The following is a description of a gene set: studied in species Homo sapiens Genes predicted to be targets of miRBase v22 microRNA hsa-miR-7106-5p in miRDB v6.0 with MirTarget v4 prediction scores > 80 (high confidence targets). Human Gene Set: MIR7106_5P from publication Chen Y, Wang X (PMID 31504780), and this is the list of marker genes: INKA2, ARID2 (NCBI Gene Id 57676), GAB2, CREB3L2, ATF6 (NCBI Gene Id 22926), ZXDA, MPP2, ANKS4B, ZNF814, SP8, PAPOLG, ARG2, IRGQ, WDR64, SARDH, PURG, MAP3K13 (NCBI Gene Id 9175), ARL6IP5, TPCN1, TMEM14B (transmembrane protein 14B), TRAF3IP2, CYP1A2, PDLIM7 (PDZ and LIM domain 7), POLDIP3, SRGAP1, DENND2B, MTFP1, ALS2, ABHD4, ENTPD5, RIMS3, BAZ2A, ANO6, HRH2, NDST1 (NCBI Gene Id 3340), CRTC2, OSBPL1A, PTPRB, PRR12, VWA5B2, AGPAT1, NCKAP1L, VPS13B, CORO2B, FNDC5, FGFBP3, PLCXD1, TMEM164, KLK4, N4BP1, HOXC10, COG5, PI3, GDF11, CES4A, TBC1D24, MIP, SDK1, CNEP1R1, GNAT1, ABCG4, PDLIM2, ACKR2 (atypical chemokine receptor 2), FBN2, BLOC1S3, NFAT5, SHISA7, BAK1, NACC1, MARK4, MAML1, TOM1L2, ERLIN2, SMUG1, CACNG7 (calcium voltage-gated channel auxiliary subunit gamma 7), CBX5, LEPROT, CGNL1, MYO10, XPO4, IMPDH1, TMEM239, TBC1D20, ZNF674, POU2F2, SCAI, SKI, VAT1, DNAJC8, DLG5, SLC25A45, DAB2IP, KANK2, GM2A (NCBI Gene Id 2760), NOS1, CEBPZOS, TMED10, ZNF544, CALCR, CDC20B, PHACTR4, APOBEC3F, MAPK13, SUSD5, TNRC6A, DERL1 (derlin 1), NCEH1, EXPH5, PACS1, ISLR, ELK1, TMEM63C, IRAK3, CCL28, EFNB3, FURIN, COPS7B, IGF2BP1, TFDP2, TEAD2 (TEA domain transcription factor 2), ITLN1, CREB5, SENP5, SPINDOC, CAST, AR, NFASC, CPLX2, PPIL3, RALB, SIDT2 (SID1 transmembrane family member 2), SLC2A4, USP54, HPDL, ZNF639, HP1BP3, EEIG1, SYPL2, AHDC1, MOB3A, SHOX, ZHX3, ZNF385A, BTF3L4, NANP, IDS, SV2C, GPLD1, RBM19, DHH, GYG2, IQSEC1, ZNF365, PFN2, FNIP1 (folliculin interacting protein 1), FTCD (formimidoyltransferase cyclodeaminase), ZNF177, POU2AF1, RBM23, PLEC (plectin), ZNF559-ZNF177, BMP8A, CYP20A1, PSORS1C1, PSMB2 (NCBI Gene Id 5690), IKZF3, SH3BP2 (NCBI Gene Id 91018), ELMO1, P4HA1, PAX2, EIF4EBP2, CDH1, VIRMA, NMNAT2, PCBD2, NECTIN1, PKP1, MDM4 (MDM4 regulator of p53), ZNF554, MARK2 (NCBI Gene Id 2011), CD164, STK25, IGFBP5 (NCBI Gene Id 3488), GIPR, MAVS, MUCL3, AVL9, ATF7IP2, TSPAN31, HNF4A, RAD51B, CS, EPS15L1, SYBU, PRKCA, EEF2K, CCND3, PAX7, NOVA2, NEK2, SORBS3, CTNNA3, ODAPH, PACSIN1, UBXN2B, NAV1, HUNK, OAS3, ATXN2L, FOXK1, PRICKLE3, ASPG, PPP1R11, KCNJ6, EFCAB2, RGS5, SLC7A8, ORAI2, SLC4A8, WFDC1 (WAP four-disulfide core domain 1), LRP4, CLSPN, ATXN7L3, RRP15, TNFSF9, FGF23, DACT2, CADM3, JPH4, ZNF501, GNAO1, STK39, MYOZ2, RPL15, HERC3, NALF1, PLEKHA5, SART1, PPIE, MPV17L, VPS25, CPNE4, KCND1, GRIP2, HDAC9, CSDC2, KNCN, ZNF354C, PAQR4, PPM1F, ZNF497, TMTC1, CASP10, MYO1D, NCR3LG1, SLC36A3, MAT2A, APOL6, PDPN, SAMD4A, SNU13, SLC6A11, AIF1L, GTDC1, THBD, FOXP4, TXNDC12, A1BG, KIAA0513, RBMS2, PNPO, TOMM40L, RNF114, LZTS3, JPH2, UBE2D4, NRIP2, RNF103, CSNK1G3, VAMP1, CENPO, HECTD4, EOGT, DEPDC5, TIAM1-AS1, SYT2, TEX261, GRID2, IQGAP1, PRND, ARF5, SYT15, GPT2, TSPYL5, DBP, ARL4D, ZSCAN26, ARHGEF11, MPIG6B, MTCL2, OGFOD1, SEPTIN3, CASTOR2, GRM5, SHISA6, KCNIP1, FBXL20, SCG2, DAGLA, KCNQ2, ARGFX, AIFM1, ACTR3B, ZNF572, PLXNA4, SLMAP, KHDRBS1 (NCBI Gene Id 10657), LRRC59, LDLRAP1, SULT1E1, NRF1 (NCBI Gene Id 4899), BACH2, BMAL2, RMND5B, VAMP2, TBL2, COL11A2, ZNF619, PXN, RPH3AL, CUX1, MTFMT, MRPL30, SYNGR1, TRAPPC3, BCL9, MASP1, GNPNAT1, LPIN3, CES5A, DTX4, SOX4, SLCO2A1, PDE7A, FUS, ZDHHC15, CDK2AP1, TCTN2, ANKRD54, KCNJ3, GNL3L, SLC35F6 (solute carrier family 35 member F6), RAB21, RAB35, NDUFA10, ATF7, NFIC, GLG1, NSG2